The following is a description of a gene set: from publication Kalia V, Sarkar S, Subramaniam S, Haining WN, Smith KA, Ahmed R (PMID 20096608) studied in species Homo sapiens Genes up-regulated in comparison of naive CD8 T cells versus effector CD8 IL2RA high T cells at. CD25, the high affinity interleukin-2 (IL-2) receptor alpha-chain, is rapidly upregulated by antigen-specific CD8+ T cells after T cell receptor stimulation. We demonstrated that during an acute viral infection, CD25 expression was dynamic, and a subset of virus-specific CD8+ T cells sustained CD25 expression longer than the rest. Examination of the in vivo fate of effector CD8+ T cells exhibiting differential responsiveness to IL-2 revealed that CD25lo cells, which were relatively less sensitive to IL-2, preferentially upregulated CD127 and CD62L and gave rise to the functional long-lived memory pool. In contrast, CD25hi cells that accumulate enhanced IL-2 signals, proliferated more rapidly, were prone to apoptosis, exhibited a more pronounced effector phenotype, and appeared to be terminally differentiated. Sustained IL-2 receptor signaling resulted in increased CD8+ T cell proliferation, higher granzyme B expression and exaggerated contraction after antigen clearance. These data support the hypothesis that prolonged IL-2 signals during priming promote terminal effector differentiation of CD8+ T cells. Human Gene Set: GSE19825_NAIVE_VS_IL2RAHIGH_DAY3_EFF_CD8_TCELL_UP, and this is the list of marker genes: RBFOX1, LDLRAD4, RHBDL3, LURAP1, SCML2, MC3R, EHD2, UTRN, SLC24A3 (solute carrier family 24 member 3), HRC, CABP5, PCDHB7, BMPR1A, CTSK (NCBI Gene Id 1513), SV2A, HLA-DOB, MYO9A, ALDH5A1, GABRB1, SLC10A1, ANGPTL1, IGSF9B, MEIKIN, NIPAL2, CSF3, RPL35, PARP8, TENM1, SLC2A4, IDS, BHLHE41, TET3, INTU, IL36A, SMIM14, ADAM12, KRT35, NCCRP1, COL6A1, TBX19, EGFR, FLYWCH2, PTPRM, KCNA2, EDAR, TRIO, CD96, MYOZ1, DNAJC17, GLB1L, RARB, FAM171A2, MAP6, EPPIN, COL5A2, SERPINF1, PLCL1, CHST1, HOXB3, LAMA5, DENND5B (DENN domain containing 5B), NAT8, BCL2L11, TSPAN7, KCND2, C2orf88, ST6GALNAC1, AMER1, DLX4, KERA, PLPPR1, NRIP2, KRT73, ITGBL1, ZBTB5, XPNPEP2 (X-prolyl aminopeptidase 2), RPL30, UPP2, ATP7B, AKAP6, ACTN1, DNAJC28, EGFLAM (EGF like, fibronectin type III and laminin G domains), EPHB1, LEP, NPY, CELF3, MS4A10, FEV, KRTAP17-1, PLPP4, SIMC1, SESN3, CORO2B, THBS2, CASQ1, TRIM2, LPAR6, RRH, SH3BP5, DUOX1, MS4A15, NREP, OR51B4, PRKCG, ARHGEF25, GPR12, WNT1, SLC14A1, ZP2, PEG3, NAPSA, TBC1D8, LARP6, CCDC172, TIMP3, SLC35F1, PPARGC1B, FOXA2, OR5P3, PCDH1 (protocadherin 1), SPATA25, IL7R, STAT1, SNED1, PRMT8, OXT, ACVR1, MMP8, GPX6, SERPINA3, SLC29A4, FMO4, LBP, CYFIP1, LYPD4, CFI, OR2C1, SATB1, RPL37A, THRSP, AZGP1, IFT88, TMEM108, RHO, RASGRP3, METTL27, HAO2, ZFX, CHD5, C16orf86, TACR2, FCGR3A, DIRAS1, AGXT, LCE2B, DUOXA2, MYO7B, ZNF420, ZNF536, TRH, C1orf105, ADAM28, H3C14, UNC5C, PGBD5, SPARCL1, CD69, BPIFB3, BTG1, TUBB4A, ZFPM2, CLSTN2, ZC3H11A (NCBI Gene Id 9877), GPC5, TM4SF4, TCEA2, SYP, PPP1R36, RPL18, TRPM5, FIBIN (fin bud initiation factor homolog), ISM1, DEPTOR, AR, SLC22A7, ADGRG3, PRKAA2, CLRN3, CARD6, ZEB2, C17orf100, LYPLAL1, TMEM266, KIFC2, CLDN4, KCNH1, TAFA5, BIRC3, PTCH2